The following is a description of a gene set: Human Gene Set: GOBP_POSITIVE_REGULATION_OF_CELL_CYCLE_PHASE_TRANSITION species: Homo sapiens Any process that activates or increases the frequency, rate or extent of cell cycle phase transition., and this is the list of marker genes: CCND3, ADAMTS1, CDK1, RAB11A, KCNA5, RDX, MIR515-1, CCNE1, FGF10, EGFR, RCC2, ADAM17, UBE2E2, PHOX2B, KMT2E, PBX1, MIR208A, CCND2, EIF4G1, RB1, CDC20, ZNF16, MIR214, CDC25B, PKP3, PLRG1, MTA3, STOX1, PLCB1, NANOGP8, CDC23, STIL, DBF4B, MBLAC1, TMOD3, WNT10B, LSM11, RPTOR (NCBI Gene Id 654218), DDX3X, CHEK2, FBXO5, CENPJ, SKA1, DLGAP5, AKT1, PPP1R10, ANAPC7, CRNN, ANAPC5, RAD51C, TFDP1, MAPK15, MIR519D, RRM2B, MAD2L1BP, NEUROG1, PAGR1, CYP1A1, MAD1L1, CDC7 (NCBI Gene Id 8317), TGFB1, DDR2, MIR221, CUL4B, MIR29A, NPM1, CDC6, ATAD5, FAM83D, MIR222, MIR520A, MIR495, PLCG2, PAF1, BRD4, TBX2, SMARCD3, CDC25A, CCND1, TERT, CCNE2, ANKRD17, MIR372, PTENP1-AS, CPSF3, ANXA1, RGCC, CUL4A, EZH2, CUL3, BIRC5, VPS4B, DYRK3 (dual specificity tyrosine phosphorylation regulated kinase 3), ESPL1, MTBP, HSPA2, PRAP1, CCNB1, RAD51B, STXBP4, ANAPC11, SKA3, CDK4, UBE2C, DTL, RRM1, NSMCE2, MIR520H, CDC25C, SIN3A, TP63, KLHL18, RRM2, DDRGK1, SASS6, MEPCE, GLI1, CDCA5, LSM10, AIF1, CDC16, MDM2, CDC73 (cell division cycle 73), CDK10